The following is a description of a gene set: species: Homo sapiens Genes up-regulated in megakaryo-erythrocyte progenitors: wildtype versus IKZF1 knockout. Regulation of lineage potential and transcriptional priming by Ikaros. New insight is provided into a bivalent regulation of lineage priming in the HSC and its lympho-myeloid restricted progeny the LMPP by the lymphoid lineage-determining factor Ikaros Whereas Ikaros is responsible for the activation of a cascade of lymphoid expression programs and for the establishment of lymphoid potential from the HSC to the LMPP it is also responsible for the repression of stem cell and erythroid genetic programs that are incompatible with further lineage restrictions emanating from the LMPP from publication Ng SY, Yoshida T, Zhang J, Georgopoulos K (PMID 19345118) Human Gene Set: GSE15330_WT_VS_IKAROS_KO_MEGAKARYOCYTE_ERYTHROID_PROGENITOR_UP, and this is the list of marker genes: ID1, C9orf40, FZR1, SSR1 (signal sequence receptor subunit 1), ECHDC1, GFPT1, DSTN, EAPP, LHX6, SELENOS, PSMD4, EEF1AKMT1, MYO7A, AGGF1, DGLUCY, NLGN2, CUL4A, UBXN2B, EIF3A, SRFBP1, WRAP73, KDM8, SPEN, DPP8, EIF4H, GAS2, TRIM27, LDAH, IFTAP, APBA3, MINPP1, TMEM33, CUL1, ERAL1, ADAM10, RBPMS2, SENP6, TPRKB, NUP88, RORC, SLC7A8, C3orf62, ZNF566, SNRPG, APOM, STMP1, SLC15A4, CD70, C5orf15, RPL14, LYRM2, SPRYD7, NXN, FAM174B, ACY1, CTR9, MAP3K7, ACO1, M6PR, TREX1, RPH3A, NUCB1, KBTBD4, RPGRIP1, NAA11, ARL16, FOXP1, FBXW11, EIF2S3, PFDN1, MDH2, POLM, CLCC1, MYCL, LNX2, TMEM109, LHX5, DBI, COX8A, CHAC2, MAGI1, CSNK2A1 (casein kinase 2 alpha 1), EIF2B5, REV1, TUSC3, CD40, TRIT1, BAG2, NBN, AFG3L2, SOX12, FDFT1, ASCC2, GLO1, TEN1, MCRIP1, ZNF277 (zinc finger protein 277), TRAP1, APOE, TFPI2, TMEM223, TOMM40L, CEP15, DYRK3, ATP5F1D, ATXN2, LMAN2, RPL22, CDK2AP1, SLFN12L, NXT1, PIGB, IDH3B, ITM2A, ANGPTL4 (angiopoietin like 4), SLF2, COQ8B, C2orf42, INTS12, DCAF4, ACO2, TYW1, LARP1, ANKRD27, RIF1, MRPS21, PRDX1, MCOLN2, GC, MRPL54, FUBP1, MRM2, C11orf24, CHST2, IMPDH2, FEM1B, HESX1, ARHGEF2, ARMC1, DYNLT4, SPEF1, ANGPTL7, ZDHHC3, ATP6V0B, ALAS1, ACTN4, EMG1, ADISSP, GTF3A, NADK, CHST15, LCMT2, TRIB1, RTCB, KPNA6, AAAS, MFN2, INPPL1, PRPF40A, RCN1, PTPRCAP, HAUS1, USP10, HDAC7, RPP14, OST4, SMN1, SNX19, POLE3, BLMH, PIGT, PFKFB3, NDUFB5, NUP160, PLAGL1, SWI5, TCOF1, TUFT1, POLR3D, HINT1, MRI1, PSPC1, MTCH2, ILRUN, INTS1, ITGB1BP1, COIL, GOLGA3, GEMIN2, GSS (NCBI Gene Id 2937), TEX261, POLR3A (NCBI Gene Id 11128), AEBP2, SRSF10, SMIM11, HIPK2, DNAJC27, ERBB3, HSPA4, PHLDA1